Given this list of marker genes GATA3, CD81, PRKCZ, RSAD2, IL4, XCL1, IL6, NLRP3, DENND1B (NCBI Gene Id 54530), here is a description of the gene set: Human Gene Set: GOBP_POSITIVE_REGULATION_OF_T_HELPER_2_CELL_CYTOKINE_PRODUCTION Any process that activates or increases the frequency, rate or extent of T-helper 2 cell cytokine production. studied in species Homo sapiens